Given this list of marker genes SPPL2C, PSEN1, SPPL2A, HM13, NCSTN, SPPL3, SPPL2B, PSEN2, here is a description of the gene set: Catalysis of the hydrolysis of nonterminal peptide bonds in a polypeptide chain, occurring within a membrane. Human Gene Set: GOMF_ASPARTIC_ENDOPEPTIDASE_ACTIVITY_INTRAMEMBRANE_CLEAVING species: Homo sapiens